The following is a description of a gene set: studied in species Mus musculus Reactome Pathway: DNA strand elongation This event has been computationally inferred from an event that has been demonstrated in another species.<p>The inference is based on the homology mapping from PANTHER. Briefly, reactions for which all involved PhysicalEntities (in input, output and catalyst) have a mapped orthologue/paralogue (for complexes at least 75% of components must have a mapping) are inferred to the other species. electronically inferred by orthology from the curated human pathway part of: Synthesis of DNA, and this is the list of marker genes: Pola2, Pold4, Pold1, Dna2, Lig1, Rpa1, Pcna, Rfc1, Pola1, Gins3, Gins1, Rfc3, Pold2, Prim1